Given this list of marker genes CDIN1, SH2B3, NCKAP1L, SLC4A1, SELENOW, SFXN1, UBA5, MIR221, GATA2, HMOX1, JAK2, NCAPG2, KLF2, G6PD, ZFP36L1, ACIN1, KCNQ1, FECH, FLVCR1, EPAS1, TAL1 (TAL bHLH transcription factor 1, erythroid differentiation factor), RPS14, SLC48A1, BCL6, DIAPH3, RAC2, MYB, HMGB2, MB, ALAS1, RPS17 (ribosomal protein S17), HSPA9, TSPO2, HSPA1B, ZFP36, NFE2L1, STAT1, HSCB, SLC25A40, RPS19, ZNF16, ADGRF5, CDK6, HSPA1A, SRF, STAT3, MIR222, MFHAS1, EPB42, RACGAP1, MAEA, ETS1, STAT5A, AHSP, ERCC2, VEGFA, SCNN1B, BAP1, PLA2G10, GATA1, BPGM, PRMT1, INHA, HCLS1, TMEM14C, HIF1A, ARNT, BBIP1, FAM210B, THRA, GATA3, ID2 (NCBI Gene Id 3398), BBS4, INPP5D, ATP5IF1, EPO, HNRNPU, AXL, TRIM58, BMP4, ISG15, CEBPG, SLC25A5, ACVR2A, VPS13A, TMOD3, LYN, PKNOX1, CDK5RAP3, BRD1, INHBA, LYAR, TCEA1, MPIG6B, HOXA5 (homeobox A5), IREB2, ABCB10, JMJD6, DNASE2, HDAC6, GPI, KAT7, MAFB, SMAD5 (SMAD family member 5), MAPK14, ETV2, ACVR1B, SPI1, SLC11A2, HIPK2, NEMP1 (nuclear envelope integral membrane protein 1), HEATR3, RPS24, TRIM10, PRKDC, ZFPM1, TGFBR3 (NCBI Gene Id 7049), RHAG, RHEX, KLF1, SLC1A5, RAC1, SMAP1, RB1, ZBTB7A, PRDX1, KIT, HBZ, P4HTM, DYRK3, UFL1, HOXB6 (homeobox B6), CHMP5, YPEL4, IKZF1, CITED2, ANKRD54, SENP1, PTPN2, RCOR1, KLF13, MIR486-1, B2M, ADAR, DMTN, MAPK11, CASP3, PTBP3, SLC25A38, ALAS2, ARID4A, SP3 (NCBI Gene Id 6670), STAT5B, GLUL, LDB1, MED1, KMT2E, L3MBTL3, FOXO3 (NCBI Gene Id 2309), here is a description of the gene set: studied in species Homo sapiens Human Gene Set: GOBP_ERYTHROCYTE_HOMEOSTASIS Any process of regulating the production and elimination of erythrocytes within an organism.